The following is a description of a gene set: The elimination of sodium ions from peritubular capillaries (or surrounding hemolymph in invertebrates) into the renal tubules to be incorporated subsequently into the urine. species: Mus musculus Mouse Gene Set: GOBP_RENAL_SODIUM_EXCRETION, and this is the list of marker genes: Corin, Comt, Drd2, Ednrb, Spx, Atp6v1b1 (ATPase, H+ transporting, lysosomal V1 subunit B1), Mllt6, Nr3c2 (NCBI Gene Id 17363), Edn1